Given this list of marker genes UGP2, UXS1 (NCBI Gene Id 80146), UGDH, SLC35D1, SLC35D2, here is a description of the gene set: Formation of the active cofactor, UDP-glucuronate studied in species Homo sapiens Human Gene Set: REACTOME_FORMATION_OF_THE_ACTIVE_COFACTOR_UDP_GLUCURONATE